The following is a description of a gene set: Human Gene Set: FUJIWARA_PARK2_HEPATOCYTE_PROLIFERATION_UP studied in species Mus musculus Genes commonly up-regulated in both non-tumorous and tumorous liver tissues of PARK2 knockout mice. from publication Fujiwara M, Marusawa H, Wang HQ, Iwai A, Ikeuchi K, Imai Y, Kataoka A, Nukina N, Takahashi R, Chiba T (PMID 18574468) The parkin was first identified as a gene implicated in autosomal recessive juvenile Parkinsonism. Deregulation of the parkin gene, however, has been observed in various human cancers, suggesting that the parkin gene may be important in tumorigenesis. To gain insight into the physiologic role of parkin, we generated parkin-/- mice lacking exon 3 of the parkin gene. We demonstrated here that parkin-/- mice had enhanced hepatocyte proliferation and developed macroscopic hepatic tumors with the characteristics of hepatocellular carcinoma. Microarray analyses revealed that parkin deficiency caused the alteration of gene expression profiles in the liver. Among them, endogenous follistatin is commonly upregulated in both nontumorous and tumorous liver tissues of parkin-deficient mice. Parkin deficiency resulted in suppression of caspase activation and rendered hepatocytes resistant to apoptosis in a follistatin-dependent manner. These results suggested that parkin deficiency caused enhanced hepatocyte proliferation and resistance to apoptosis, resulting in hepatic tumor development, partially through the upregulation of endogenous follistatin. The finding that parkin-deficient mice are susceptible to hepatocarcinogenesis provided the first evidence showing that parkin is indeed a tumor suppressor gene., and this is the list of marker genes: SULT1E1, FST, ABHD1, TFB2M, APOA4, HSD3B1, APCS, ASNS, HSPA1A, NAT8